Given this list of marker genes COL9A1, COL9A3, PTH1R, CHD7, STAG2, RUNX2, POLR1C, ELN, IPO8, TBX4, AGL, RHOA, MAP2K2, HNRNPH1, SOST, BUD23, LRPPRC, STX1A, TONSL, LAS1L, ARID1B, DHODH, MAPK1, COG4, TBL2, LARP7, SEC23A, CRELD1, POLR3A, KRAS, PYCR1, RFX7, INPPL1, POR, KCNH1, NONO (non-POU domain containing octamer binding), EIF4H, TFE3 (transcription factor binding to IGHM enhancer 3), ASPH, PEX12, CTDP1, DCHS1, HDAC4, SETBP1, TFAP2B, MLXIPL, NOTCH3, SHANK3, ATP6V1A, SLC35D1, PEX1, RAB3GAP1, RNU12, TGFBR1, MAF, ERI1, KIF7, COL2A1, MBD5, BBS7, AMMECR1, ATP6V0A2, FAT4, NOTCH2, FAM50A, UBE2A, NGF, ADAMTSL4 (NCBI Gene Id 80075), POLR1B (RNA polymerase I subunit B), DNAJC30, FOXP1, LIMK1, EHMT1, DVL1 (dishevelled segment polarity protein 1), RNU4ATAC, NBAS, UFD1, NCF1, SEMA3E, PIGA, COL9A2, CCBE1, FAM20C, YY1, FGFR2, CANT1, EBP, PDZD8, FOXC1, TBX1, ACAN, GORAB, FGFR1, EFTUD2, B3GALT6, KCNE5, PRMT7, GP1BB, XRCC4, SCARF2, FLNB, TGFB3, TBL1XR1, TGFBR2, NBN, FKBP6, ATRX, COL1A1, RFC2, POU1F1, PIGV, COMT, GRIA3, PIK3R1, NECTIN1, BAZ1B, ASXL3, DLG3, GLI2, RREB1, NSMCE2, PEPD, LMNA (NCBI Gene Id 7816), KCNJ2, NEK1, SERPINH1, POGZ, PCGF2, PIGT, SF3B2, ERF, SLC6A8, SMAD3, TMEM237, RAI1, CDH11, HBA1, PLOD3, GPC6, SLC2A10, RAB3GAP2, AIFM1, MAN1B1, HS6ST2, POLR1D, BMP2, PAX3, TWIST1, PYCR2, BRAF, SETD2, BMP4, MAP2K1, SHH, TWIST2, BGN, DNMT3B, VPS13B, SNRPB, ACSL4, CDK10, GSC, COL11A2, POLR1A, LRP2, PIGU, VPS37D, ATP6V1E1, ZBTB20, HIRA (NCBI Gene Id 7290), CNOT1, COL11A1, DDR2, CHD6, SIX3, TCOF1, RSPRY1, ESCO2, NSDHL, WNT5A, NTRK1, TMEM165, PEX7, GTF2I, RDH11, CNOT3, NDP, LRP4, PSMC3, FBN1, BUB1B, HERC1, TGDS, GJA8, GJA5, COL5A1, MED12, MECP2, OBSL1, SATB2, PQBP1, GTF2IRD1, RLIM, TFAP2A, PDE4D, METTL27 (methyltransferase like 27), TMEM270, POMGNT1, HSPG2, HBB, POLE, RPS26, SMAD2, MAN2B1, OFD1 (NCBI Gene Id 8481), SF3B4, SEC24C, CA2, ZFX, CRKL, KIF22, HBA2, BLM, TP63, RAB23, GTF2IRD2, NPR3, CUL7, TAT, MGP, BCR, CLIP2, FZD2, MYH3, TBX22, ANKH, FGFR3, JMJD1C, ARVCF, RBM8A, ROR2, ZNHIT3, HDAC8, LIFR (NCBI Gene Id 3977), LTBP4, TGFB2, SLC26A2, APC, NF1, SMAD4, FLNA, here is a description of the gene set: An abnormality of the zygomatic bone. Human Gene Set: HP_ABNORMAL_ZYGOMATIC_BONE_MORPHOLOGY Abnormal zygomatic bone morphology species: Homo sapiens